The following is a description of a gene set: species: Homo sapiens from publication Chen Y, Wang X (PMID 31504780) Genes predicted to be targets of miRBase v22 microRNA hsa-miR-12114 in miRDB v6.0 with MirTarget v4 prediction scores > 80 (high confidence targets). Human Gene Set: MIR12114, and this is the list of marker genes: OAS1, ZBTB20, ATRNL1, CACNA1E, HRNR, OPA3, RIMS3, TUSC3, BTF3L4, TREML1, SMG1, MS4A3, ZNF91, TSC22D3, ATF7IP, PCDHGA7 (NCBI Gene Id 56108), EPHB1, FMNL3, STRN, PPP2R1A, PIP4K2B, NIBAN3, BBOF1, ZNF618, CTR9, MPV17, ZC3H15, PHF20, ZNF555, USP54, CTSV, NOTCH2NLA, ZNF519, TMEM229A, VCPIP1, FNIP2, CDC14B, ATXN7, GJA9, ZNF234, DOCK8-AS1, CFAP161, SLC8A3